Given this list of marker genes DMAC2, DAAM1, CPLANE2, DRAP1, RRM1, CDK4, HLA-DRB1, PTPN4, FHL1P1, LINC00265, SERBP1, MORC3, RNF114, GLA, RACGAP1, RHOF, LINC00877, IGHMBP2, MRPS11, SUV39H2, TOM1L2, COX20, TRAPPC2L, NAPA-AS1, RPAP1, KCNQ1OT1, MAP3K14, HOOK2, HDAC4-AS1, FBXO38-DT, NUDCD3 (NudC domain containing 3), FASTKD2 (NCBI Gene Id 22868), PCF11, CLIC4, SEPTIN7P14, SULT2B1, COX14 (NCBI Gene Id 84987), SPNS1, DCAF6, RSF1, USP1, MAP4K1, RPL7L1, TTC8, SNX8, ZNF20, SMARCD2, CBX3, ATP5MF, CTB-30L5.1, NOXO1, POLDIP3, FLVCR1, TMEM94, MBD2, RBM5, KANSL3, MRPL52, SPRYD3, HMGB1, MIR320A, NFIA, LRRC8A, DOHH (NCBI Gene Id 83475), LEMD3, MSANTD2-AS1, SLC5A6 (solute carrier family 5 member 6), MCMBP, PACS2 (phosphofurin acidic cluster sorting protein 2), SERTAD1, PTCD1, CYP46A1, LEMD2, DDX5 (DEAD-box helicase 5), NCOA5, SNORD95, KCTD5, UBE2G1, FBXO16, KBTBD4, ATE1, DNAJC30, CUX1, ZNF821, HDAC4, FAM193B-DT, MPC2, PISD, MED25, INO80C, RTN4IP1, ATG4D, RUVBL1, PUF60, GASAL1, ZNHIT1 (zinc finger HIT-type containing 1), ZNF70, MT-ND1, AKT1S1, MED4, PRUNE1, LINC01089, SENP6, BRIX1, RAF1, CCDC115, ENSG00000231119, TXNDC15, TAF3, COMT, EMG1, FEM1A, CHD2, DRC3, MTMR12, PIK3IP1, USP24, LINC02614, DAXX, DEPTOR, ZNF791, RILPL2, GDI1, SLC39A7, PPP2R5D, POGLUT1, SZRD1, WASHC4, GART, PHGDH, NRF1, SNRPF-DT, COQ4, TARDBP, FOXN3, TXNL4B, IMMT, TIMM44 (translocase of inner mitochondrial membrane 44), MSH2, TYK2, SEPTIN7, TRIR, CCDC167, WDR82, GTPBP1, DMAP1, VPS16, ZFC3H1, MRPS15, CATSPERD, QTRT1, RIPOR1, EPM2AIP1, PRANCR, CAB39L, ZPBP, YARS2, AMD1, CUTA, LMTK2, DNAJB1, LNCRNA-IUR, EIF2B5, SMIM27, COMMD9, MRPL46, ST3GAL3, TMEM243, RRP15, HIPK1-AS1, FASTK, ODC1-DT, ZNF507, SEC24C, MRPS30-DT, TOR1A, MINDY1, CTNNB1, AGA, TSPYL1, SLC43A2, KIAA0319L, ACTR3B, RCC1L, RXRB, IFT57, TEPSIN, BUD23, SFPQ, NGDN, H2AC6, FTSJ3, TTLL3, ZNF688, RSPH1, TRIM69, SRSF2, CAMLG, SLC25A44, PPP1R21, NFKBIB, METTL3, HAUS5, PSKH1, TJP3, ID2, ZFP91, PRDM10, GSK3B-DT, CYC1 (cytochrome c1), SMG5, PLOD3, ZFX-AS1, XRRA1, NEK10, NR3C1, REXO1, SAE1, MZT2B, ZNF649 (NCBI Gene Id 65251), GOT1-DT, ELL, PLA2G6, MIR22HG, SCRIB, ILF3, GHITM, FAM86JP, DHRS7B, NDUFA13, LSG1, C12orf57, WIPF2, EXOSC5, CUEDC2, C12orf43, FAM117A, ZMYM5 (zinc finger MYM-type containing 5), BTN3A3, MPDU1-AS1, ZNF143 (NCBI Gene Id 7702), LSR, PDCD4, ATRX, GATB, ADGRL1-AS1, MRPL3, SAMM50, BRF1, RNF220, DNAJC11 (DnaJ heat shock protein family (Hsp40) member C11), MAU2, ZNF614, PPP2R1B, AIDA, IPPK, CASD1, QRICH1, FBXL18, DMTF1-AS1, PPP1CC, PSMA2, NCK1-DT, TSPAN10, NCOR1, HLA-B, HLA-DQB1, CRK, ZNF585B, CIAPIN1, ALG1 (NCBI Gene Id 56052), AEBP2, ATXN10, CARD8, HLA-DMA, MFF-DT, PHB2, NAA60, SLC2A1, KAT6B, RPN1, ZFAT, OSR2, FLVCR1-DT, FAM107B, ABL2, LINC01596, PTBP1, IQCH-AS1, SYT7, LRRC41, MT-CYB, ZNF613, PNRC1-DT, NRSN2-AS1 (NRSN2 antisense RNA 1), TRIM26, MT-CO1, AURKA, MICU2, HLA-DPB2, QTRT2, SBNO1 (NCBI Gene Id 55241), TP53, AAGAB, LRBA, TAX1BP3, N4BP1 (NEDD4 binding protein 1), CSNK2A1, XPO4 (exportin 4), SNORD3A, HLA-DMB, CARS2, ERAL1, RPTOR, BCKDHA, NLRP11, MAP1LC3B, GFI1B, NUP62CL, UBE3B, AHNAK, MCM5, UFC1, TRAF3IP2-AS1, MKNK2, NUP188, ZNF574, NELFA, BTBD6, COMMD7, DDX39B-AS1, ZFYVE26, EVI5L, MRPS18B, BTN2A1, LRRC51, CLK3, WDR18, PSMA5, FAM193B, ELOB, PHLDA1-DT, HNRNPH2, DIP2A, RPL12 (NCBI Gene Id 90679), BLOC1S3, TSEN34, B9D1, SNX13, MTHFD2, PRDM10-DT, INO80B-WBP1, XXYLT1, PDE6D, MCCC1, FARSA, ENSG00000263280, BRD2, ATP5PD, ARMC1, H3-3B, BLTP3B-DT, TIMM50, SMPD4, RAB40C, MFSD14A, PTCD2, DIAPH1, VPS26BP1, MIRLET7IHG (MIRLET7I host gene), RNU12, ZNF484, MYDGF, GARS1, ZBTB40, CRADD, RAB11A, USP31, PHLDA1, UBE2D3, MAP9, CDKAL1, ZNF268, CSNK1A1, SLC2A12, PCBP1-AS1, RPA2, TNFAIP8, RNF187, MTF2, CCT6B, ZBTB11, EML6, PRKCZ, FHIT, TOMM40L, ZNF793, PAGR1, ITPA, TMEM217, MRPL20, RABGGTB, SNRPA, ZC3H11A, COPS4, PPP4R3A, RNU7-27P, RBM33-DT, THADA, TAF4, DDIT4, CAT, B9D2, DNAAF5, SPCS2, SWT1, KLLN, PEX1, CLN3, HLA-L, STAG2, FAM204A, SNORD84, PICALM, RPL13A, DSE, EIF2B5-DT, TRIM14, THAP2, NOM1, CTU1, UBIAD1, DPAGT1, ZNF432, HEXIM2, NR1H3, PUM1, ATP13A1, PREPL, NDRG3, GNL3L, SCAF8, DYNC2I2, RAD1, COX10 (NCBI Gene Id 1352), SLMAP, GNAI2, TMX4, KCTD10, ENTR1, TMEM11, SHLD1, SEPTIN7P2, SLC2A1-DT, CABIN1, FSD2, COPS7B, TOE1, CEP164, PIGU, CHTOP, MFSD5, LINC02960, SPPL2B, TPGS1, SRRT, MARK3, RAB6A, METAP1D, UBB, ACTB, MAP7D3, FSIP1, GTF3C6, PSMD3, GIHCG, MAPRE2, CCDC124, ZBTB17, TSPYL2, MAP2K5-DT, DYNC1LI2-DT, MEMO1 (mediator of cell motility 1), DEDD, FBXO38, SPAG7, QSOX2, CEP43, PDXP-DT, HLA-F, TTC9C, SUPT7L, ZNF672, DENND4A, DCP2, RBM42, UFD1, MAP2K5, PJA2, MPDU1, CEP120, XKR6, CCDC174, MT-TI, MKKS, PRR14, MRPS35, UBC, ACTMAP, FABP5P3, CEP350, ATF4, KMT2E, MRPL47, TM2D3, SHOC2, WDR90, TIMM10, NFYC, IDH3B-DT, IDH3B (NCBI Gene Id 3420), RBM28, PRPSAP1, ISCU, EIF3F, MFF (mitochondrial fission factor), TAP1, CDK19, AFF1 (ALF transcription elongation factor 1), WBP1, MDH1B, YPEL2, TFCP2, NDUFB5, TYW5, CPNE1, ENSG00000283078, HSF1, EGR1, BTN3A2, MT-ND6, MIB2, GTF2IP13, CFAP251, MED28-DT (NCBI Gene Id 121232375), OTUB1, KEAP1, REC8, WRAP53, TCP11L1, PPCDC, RLF, ZC3H4, ALG12, ZNF253, MRPS28, SCYL3, HACD2, CNOT1, CCDC142, BTN2A3P, APTR, OXA1L-DT, GOLPH3L (NCBI Gene Id 94793), ODAD3, LSM5, GTF2IP12, MXD4, NABP1, ZNF747-DT, VAC14, PARVG, FBXO28, RNA5SP283, TP53INP1, EXOSC2, TULP3, TSC22D1, ATF6B (activating transcription factor 6 beta), ATXN7L2, ADPRS, GRPEL1, SFSWAP, CKAP2-DT, TSC1 (NCBI Gene Id 7248), RPS6KA5, TOP2B (NCBI Gene Id 7155), HCG14, TTC16, B3GALT6, KATNB1, TBC1D14, NICN1, IL20RB, SLC25A46, ZFP91-CNTF, ADNP, NDC80, STRN4, METTL4, ZNF584, DDX17, PABPN1, NDUFA2, CCDC43, CELF1, PEX16, PRMT5, PTRH1, TIMM8B, FRG1HP, RPF2, POLR1C, TXNRD2, MRPL1 (mitochondrial ribosomal protein L1), TUBA1A, C11orf68, PYM1, CYB561A3, CALM2, UBE2L3, RAB4B (NCBI Gene Id 53916, RAB4B, member RAS oncogene family), SRRM2, SDCBP2-AS1, HLA-DQA1, GATAD2A, HIPK1, TTLL11, HNRNPUL1, GUSB, NUP35, VPS50, ZNF185, THAP4, CCDC59, ZNF830, PRKCZ-DT, RAD23A, NUMA1 (nuclear mitotic apparatus protein 1), ACTR8, SLIRP, SMIM30, DHX29, STK10, HLA-DRA, YIPF3, ZC3H6, SLX4IP, ECE2, NAGPA, ZBED5, EPC1, OXSR1, SOX12, CCDC191, NECAP1, DNAI3, ATE1OSP, BAX, PPP3R1, SCFD1, ALG3, TECPR2, EIF3B, PRSS2, RPRD2, MLEC, TMED10, WWOX, MRPS30, CENPL, AP2B1, REV3L, RBM25, ALKBH1, ACTR1B, C17orf75, OLFML2A, OSBPL11, UBA52, NXPH4, PSMB8, KDM4A-AS1, LINC00665, DNAJC1, XPO6, PRMT5-AS1, TVP23B, IQCH, DDX41, DOLPP1, NCBP3, MRPS24, KCTD21-AS1, KDM6B, RNF169, AP4S1, MKLN1, MIR3124, ARL15, TMEM231, TRUB1, HLA-DOA, NUBPL, KTI12, KDM5C, TSSK6 (testis specific serine kinase 6), ZNF175, GADD45GIP1, AP3D1, HSD17B12, TAF15, MT-TW, SARAF, CDNF, SESN3, C15orf61, RBM12, SPHK2, KNTC1, CEBPB, MRPL21, SRSF5, TAF8, AKAP10, DHX9, CCDC90B, IST1, POLD2 (DNA polymerase delta 2, accessory subunit), MYLK-AS1, ATP6V0C, MRM3, ZC3HC1, ZNF41, LIMD1, TMEM187, INO80, LINC02453, LPXN, MIR4522, PNRC2, HLA-DPA1, ARMC8, TMA16, ATP6V0A1, OTOA, BAD, RBM33, SUV39H2-DT, RCL1, CCDC90B-AS1, UQCRH, KMT5B, BLTP3B, UBE2D3-AS1, DARS2, OXA1L, ILF3-DT, PCIF1, DDB2, GEMIN6, MRPS35-DT, PCGF2, SETDB2, EPS15, WDR48 (NCBI Gene Id 57599), TRUB2, MUTYH, MSGN1, ATRAID, MYO1A, GNPTG, GALNS, PM20D2, GANAB, HCP5, RAP2A, SIRT1, CEP95, LTBP4, STOML2, CCDC13, FAF2, USE1, KAT6A, SYBU, PSMB7, ASF1B, FARS2, PATL2, SH3BP5L, TBC1D22B, NUP42, TANGO6, ETAA1, B4GALT3 (beta-1,4-galactosyltransferase 3), GLOD4, GPATCH4, BROX, MT-TQ, KYAT1, QRSL1, SEC23IP, ALG8, PSMD8, COQ9, MSANTD2, TM2D1, PTPRCAP, GET3, SEC62 (NCBI Gene Id 7095), ZNF207, TBC1D2, BRPF3-AS1, TRAPPC6A, ZMAT2, DUSP12, RPS27, RAB7A, SBNO1-AS1, EML2, AIM2, TRMT13, ENTPD1-AS1, CNPY4, LYRM4, NDUFS2, ZNF689, DDX39B, RBM15-AS1, CPEB4, PTMA, GFER, GOLGB1, ARHGEF1, LARS2, RNU5D-1, RNVU1-27, CLK1, HLA-DRB9, RBM48, DIRC3, ZBED5-AS1, RNU7-1, RBM15, PPP4R1L, KRR1, SRSF3, MAIP1, DGLUCY, NCDN, BRPF3, SON, NUBPL-DT, EEF1A1, GUSBP11, CKAP2, CCDC117, PPP1R21-DT (NCBI Gene Id 118568827), ATG14, MANBAL, NDUFS3, COG1, SNORD45C, LINC01993, NFE2L1, FAM174B, HEXIM2-AS1, CXXC1, GPR137, MIRLET7I, MFSD11, NCK1, PPRC1, METTL25, DHX38, LRRC59, OTUD5, CWC22, KNSTRN (kinetochore localized astrin (SPAG5) binding protein), BCL2L13, TBL3, LONP1, CAMKMT, KIF15, NUDT3, LINC02139, PNRC1, MCL1, TAOK2, HMGCL, NDUFAF8 (NCBI Gene Id 284184), PDXP, KLHL28, MT-TL1, DOT1L, MED28, MT-TF, PTAR1, TBC1D17, NDUFA9, MFSD6, GPATCH3, MRPL32, KHDC4, TCAIM, PPT1, CATSPERG, OSCAR, SIRT2, GTF2A1-AS1, TRA2B, MED13, PIK3R3, ARMC5, PFDN4, FAM222B, PPP1R10, CHCHD5, COMMD10, CBX6, APTX, DYNC1LI2, HNRNPUL2, SRSF1, EIF4G3, OR2I1P, ING3, EIF4E, DGKA, PDE4B, PPP6R1, MOSPD3, DUSP28 (dual specificity phosphatase 28), MTREX, PTRHD1, ARHGEF37, GBF1, SYNRG, LSP1, LRCH3, YWHAZ, NASP, BTN2A2, ODC1, TMX4-AS1, IMP4, COPS6, NDUFA3 (NCBI Gene Id 4696), RPL35A, FTH1, HCFC1, CSTF2T, USP47, UTP20, USF1, TTC17, TOMM22-DT, PSMC3, AP1G1, TMEM39A, C7orf25, NAA35, DERL3, CRAT, LINC01560, MORF4L1, VPS35L, SPTLC1, VPS53, CCNG2, TMEM79, GOT1, RSPH1-DT, MR1, CENPU, DIDO1, PLPBP, SRCAP (Snf2 related CREBBP activator protein), TRMT12, EPC1-AS1, YWHAQ, SIK3, TOR1B, FBXO31, SEPTIN7-DT, SNRPF, ATF1, CACYBP, PRMT5-DT, CIPC, SREK1, LINC01094, ZNF556, TTC31, KAT5, IKZF5, ZNF81, CDK5RAP2, DOLK, MBOAT7, DMWD, MEF2C, MXD1, RCE1, ATP2B4, CD74 (NCBI Gene Id 972), SELENOS, SMTN (smoothelin), ARRDC3, ZNF490, PPP1R3F, GIT2, COQ5, CRELD2, CKS2 (NCBI Gene Id 1164), AIP, EIF5, LRSAM1, ZNF764, GTF2A1, ZNF747, TM9SF4, SRP68, ECSIT, BBIP1, C2orf92, BTN3A1, RBM23, AKAP3, DAD1, DNAJC7, TANK-AS1, HNRNPM, VCPKMT, PSMC5, C2CD2L, PEX14, SLC9A1, ANKRD13A, SLTM, ATG4B (autophagy related 4B cysteine peptidase), IK, ECH1, CHASERR, MLH1, RMI1, MTO1, TMEM131, LSM7, HNRNPUL2-BSCL2, STAM, TAB1, ZNF585A, UTY, GLI1, VCP, PKN2-AS1 (PKN2 antisense RNA 1), UQCC2, SENP2, PSMB9, KPTN, FKRP, XRCC1, VPS26C, HLA-E, TCAM1P, PLGRKT, ADAMTSL4-AS1, RSBN1L, DLG4, RBM39, KMT2C, ERH, ZNF295-AS1, SUGP1, PDF, PTPA, RAB40B, ARID1A, RAB4B-EGLN2, GALNT16, HLA-DPB1, ZNF793-AS1, TAF6, ARAP1, CIC, FAM111A-DT, TSPYL4, WSB1, BSCL2, YWHAE, LIN7C, LRRC14, UBE2V2, PER1, TMEM138, ATP5MF-PTCD1, KDM4A, RACK1, ZNF487, SDF4, POLR3D, ACADSB, DNAAF6, GNAS, BAZ1A-AS1, COX10-DT, ACP2, RFX5, SNX1, SNX12, MOB3A, EIF2D, STAG2-AS1, KAT7, ARFGEF2, IFT46 (NCBI Gene Id 56912), HLA-A, AAMDC, ZNF615, RAB22A, TMEM30A-DT, RUFY1, PMPCA, HSPA14 (heat shock protein family A (Hsp70) member 14), FNBP1P1, DOCK4, B2M, TRMT1L, KNL1, ENSG00000246308, IQCG, SRSF7, PRKCSH, IPO8, MRPS27, SLBP, ESCO1, PI4K2A, ZBED6, WBP1L, AKAP13, SRRM3, SLC17A5, UBE2N, BOP1, NARS1, DYRK1B, KANSL2, HLA-DOB, PCED1A, SDHD, PPP1R12B, EIF3K, SLC4A1AP, FUZ, GARS1-DT, SLC7A7 (NCBI Gene Id 9056), SLC39A9, RNVU1-30, TSR3, TOR2A, IP6K2, RPS2P1, PHF8, PTEN, CENPO, GRIK5 (NCBI Gene Id 2901), HNRNPC, ATP8B1-AS1, CCDC34, EIF4H, ZFAND4, C12orf56, GRWD1, NOP53 (NOP53 ribosome biogenesis factor), INO80B, ING4, TMEM101, ARHGEF40, GSK3B, CDC45, BDNF-AS, EIF3E, MKLN1-AS, CCND3, CDKN2D, ECI1, KCTD2, CSTF1, ADK (NCBI Gene Id 132), CNOT2, UBN2, ATF7IP, DIAPH1-AS1, RBM15B, KIAA1143, LMF1, PLCXD2, DNLZ, MRPL38, TMEM232, PLK4, MT-RNR1, ZNF143-AS1, KCNF1, ZNF273 (NCBI Gene Id 90816), EIF4G2, RCAN1, MRPL44, RPS11, TAB3, MFSD13A, SLC25A12, SASS6, USP21, NDUFS7, TOMM22, TMEM11-DT, ZNF429, MIR3667HG (NCBI Gene Id 348645), TIMM22, PDHB, STRIP1, C1orf174, HLA-C, PKM, TPP1, TCERG1, HAUS5-DT, MAP3K7, PCNX1, HLA-DRB5, here is a description of the gene set: studied in species Homo sapiens from publication Yevshin I, Sharipov R, Kolmykov S, Kondrakhin Y, Kolpakov F (PMID 30445619) Genes containing one or more binding sites for (CIITA) in their promoter regions (TSS -1000,+100 bp) as identified by GTRD version 20.06 ChIP-seq harmonization. Human Gene Set: CIITA_TARGET_GENES